The following is a description of a gene set: from publication Cao J, O'Day DR, Pliner HA, Kingsley PD, Deng M, Daza RM, Zager MA, Aldinger KA, Blecher-Gonen R, Zhang F, Spielmann M, Palis J, Doherty D, Steemers FJ, Glass IA, Trapnell C, Shendure J (PMID 33184181) The gene expression program underlying the specification of human cell types is of fundamental interest. The study authors generated human cell atlases of gene expression and chromatin accessibility in fetal tissues. For gene expression, the study authors applied three-level combinatorial indexing to >110 samples representing 15 organs, ultimately profiling ~4 million single cells. The study authors leveraged the literature and other atlases to identify and annotate hundreds of cell types and subtypes, both within and across tissues. Our analyses focused on organ-specific specializations of broadly distributed cell types (such as blood, endothelial, and epithelial), sites of fetal erythropoiesis (which notably included the adrenal gland), and integration with mouse developmental atlases (such as conserved specification of blood cells). These data represent a rich resource for the exploration of in vivo human gene expression in diverse tissues and cell types. Marker genes curated from the annotated cluster as represented in the Descartes Human Gene Expression During Development database. Human Gene Set: DESCARTES_FETAL_EYE_PHOTORECEPTOR_CELLS studied in species Homo sapiens, and this is the list of marker genes: LINC02058, NPTX1 (NCBI Gene Id 4884), EYS, LINC01915, RPL30P7, KCNV2, PRICKLE2-AS1, LINC03062, DRGX, PDC (phosducin), TMEM244, MTCO1P15, ST3GAL3-AS1, SUSD2, LRIT2, IMPG1, EGFLAM-AS1, EGFLAM, LINC00575, CERKL (NCBI Gene Id 394232), MAK, LINC00463, MTATP6P15, ATP6V0D2, OLAH, LINC01053, SAMD7, USH2A, UNCX, MPPED2-AS1, PRICKLE2-AS2, MPP4, GNAT1, PCAT4, C7orf33, RPL18P11, LGALS9DP (galectin 9D, pseudogene), GNAT2, COX5BP2, HOTAIRM1, MTCO2P15, GPC5, CNGB1, IMPG2 (interphotoreceptor matrix proteoglycan 2), LINC00457, MTND1P36, CHRNB4, RPGRIP1, GPC5-IT1, KDM4A-AS1, HTR1F, CDHR1, LINC02932, TERT, SSTR5-AS1